Given this list of marker genes SHC1, HRAS, PTPN11, KRAS, GRB2, PIK3R2, DOK2, ANGPT1, PIK3R1, PIK3CA, SOS1, TEK, PIK3CB, NRAS, GRB14 (growth factor receptor bound protein 14), ANGPT4, GRB7, ANGPT2, here is a description of the gene set: studied in species Homo sapiens Reactome Pathway: Tie2 Signaling part of: Cell surface interactions at the vascular wall The Tie2/Tek receptor tyrosine kinase plays a pivotal role in vascular and hematopoietic development and is expressed exclusively on endothelial lineage. Tie2 interacts with a group of ligands belonging to angiopoietin family and undergoes activation.<br>These ligands show opposing actions, angiopoietin 1 and angiopoietin 4 stimulate the Tie2 phosphorylation and angiopoietin 2 inhibits it. Upon tyrosine phosphorylation Tie2 acts as a scaffold for various signaling proteins involved in different signal transduction cascades that can effect survival of endothelium and angiogenic sprout formation.